The following is a description of a gene set: Transcripts depleted in pseudopodia of NIH/3T3 cells (fibroblast) in response to the chemotactic migration stimulus by lysophosphatidic acid (LPA). species: Mus musculus from publication Mili S, Moissoglu K, Macara IG (PMID 18451862) RNA localization is important for the establishment and maintenance of polarity in multiple cell types. Localized RNAs are usually transported along microtubules or actin filaments and become anchored at their destination to some underlying subcellular structure. Retention commonly involves actin or actin-associated proteins, although cytokeratin filaments and dynein anchor certain RNAs. RNA localization is important for diverse processes ranging from cell fate determination to synaptic plasticity; however, so far there have been few comprehensive studies of localized RNAs in mammalian cells. Here we have addressed this issue, focusing on migrating fibroblasts that polarize to form a leading edge and a tail in a process that involves asymmetric distribution of RNAs. We used a fractionation scheme combined with microarrays to identify, on a genome-wide scale, RNAs that localize in protruding pseudopodia of mouse fibroblasts in response to migratory stimuli. We find that a diverse group of RNAs accumulates in such pseudopodial protrusions. Through their 3' untranslated regions these transcripts are anchored in granules concentrated at the plus ends of detyrosinated microtubules. RNAs in the granules associate with the adenomatous polyposis coli (APC) tumour suppressor and the fragile X mental retardation protein (FMRP). APC is required for the accumulation of transcripts in protrusions. Our results suggest a new type of RNA anchoring mechanism as well as a new, unanticipated function for APC in localizing RNAs. Mouse Gene Set: MILI_PSEUDOPODIA_CHEMOTAXIS_DN, and this is the list of marker genes: Cpsf7 (NCBI Gene Id 77197, cleavage and polyadenylation specific factor 7), Snrnp48, Pcdh19, Pabpn1, Arhgap17, Slc38a10, Lamc1, Sfi1, Slc4a7, F3, Adnp2, Bmp1, Slc19a1, Gpr108, Son, A130012E19Rik, Rpap1, Adora2b, Slc11a2, Cnnm2, Bcl9, Sfpq, Ggcx, Twsg1, Akap1, Slc1a4, P4ha1, Hsd17b12, Fos, Zfyve27, Nisch, Ankrd11, Sri, Cds2, Pisd-ps1, Tap2, Slc10a3, Slc2a10 (NCBI Gene Id 53907), Mfsd11, Galnt18 (NCBI Gene Id 72885), Lime1, Aplp2, Rpn2, Edem2, Ss18l1, Abhd12, Nfib, P2rx4, Slc7a6, Nagk, Alkbh1, Ddr1, Puf60, Fgf7, Ecm1, Rnf10, Fn1, Gm50012, Dpf2, Nedd4l, Pld3, Dhx30, Fgfr1, Npr2, Hnrnpdl, Lmbrd1, Steap3, Chpf2, Cd9 (NCBI Gene Id 12527), BC004004, Noc2l, Fosb, Gla, Tor1b, Cldn9, Rpl30, Ube2i, 5330406M23Rik, Krit1, Neu1, Pdia5 (NCBI Gene Id 72599), Rrbp1, Atat1, Snx14, Atrn, P4ha2, Abcc1, E4f1, Mast4, Col4a1, Slco2a1, Ttc19, Plxnb2, Cyp4f16, Thrap3, Dnaaf9, Cnot3, Ephb4, Kcnq1ot1, Snx29, Dag1, Rnps1, Eif1, B4gat1, Slc29a1, Tctn1, Mfsd9, Sema4c, Birc2, Fzd7, Sigmar1, Nrp2, Ddost, Pik3ip1, Zswim8, Axl, A430046D13Rik, Rpl41, Hmgcr, Ly6e, Phb2, Plxna3, Rack1, Fads3, Gaa, Pofut1, Atp13a1, Col4a5, Esd, Polg, Tm9sf1, Ptpra, Rbm39, Tln1, Sf3b3, Fibp (fibroblast growth factor (acidic) intracellular binding protein), Slc44a2, Ap2a2, Chka, Trim35, Dido1, Cald1, Sec61a1, Baiap2, Igf1r, Cspg4, Tmem109, Tpbg, Klf3, Slc35f6, Spns1, Ackr3, Adamts5, Kdm6b, Gpaa1, Colgalt1, Ppt1, Rusc2, Tm9sf2, Oga, Serpine1, Rps24, Hmgcs1, Angptl2, Syvn1, Srebf2, Tm2d3, Col16a1, Pdgfra, Btg1, Slc38a4, Timp2, Gsk3b, C1s1, Scpep1, Matn2, Fam171a1, H2-DMb1, Serinc1, Med15, Nrp1, Slc35a2, Riok1, Qsox1, Igsf3, Hacd3, Sfswap, Gas5, Clstn1, Naa40 (N(alpha)-acetyltransferase 40, NatD catalytic subunit), Serinc3, Slc20a2, Ppp1r10, Mfsd14b, Slc12a9, Mtch2, Plod1, Nceh1, Slc39a14, Nfkbiz, Arel1, Dhrs7, Clic1, Zdhhc5, Sptlc1, Chuk, Armc9, Atp1a1, Sppl2a, Ltbp4 (NCBI Gene Id 69644), Ranbp3, Abcc5, Adamtsl4, Pla2g7, Clcf1, Prnp, Dolk (dolichol kinase), Trps1, Pan3, Cd109, Rara, Fbln2, Mst1, Pi16, Glg1, Lhfpl2, Tyw1, Slc23a2, Chst12, Ganab, Tmed7, Gcn1, Tlr2 (NCBI Gene Id 24088), Ndel1, 2610005L07Rik, Abca3, Naglu, Akr1b10, Fus, Gmcl1, Mir1949, Itga5, Rbx1, Txndc5, Ldlr (NCBI Gene Id 16835), Mfsd10, Plat, Lrp12, Slc30a6, B3gnt2, H2-K1, Smg5, Pigm, Vcl, Poldip3, Emilin1, Rgs3, Lncppara, Sun2, Khk, Socs3, Erh, Ppil2, Pdia6, Sema3f (sema domain, immunoglobulin domain (Ig), short basic domain, secreted, (semaphorin) 3F, NCBI Gene Id 20350), Hspa5, Wls, Nhlrc3, Grn, Ubtf, Col5a1, Lox, Sec61a2, Thbs1, Sema3b, Vasn, Vcp, Rpn1, Gmpr2, Tnfsf9, Slc16a1, Lrrc8c, Ccnt2, Ttc7, Pdgfrb, Hsf1, Dgcr2, Col4a6, Tubgcp4 (tubulin, gamma complex component 4), Agfg2, Fzd2, Epb41l2, Poglut2 (protein O-glucosyltransferase 2), Malat1, Scfd1, Slc20a1, C1ra, Sgpl1, Selenos, Klf6, Gprc5b, Tmem43, Slc38a2, Thbs3, Serpinf1, Slc12a4, Acvr1, Zzef1, Gnb1, Npc1, Zfp266, Nono, Mpzl1, Tmppe, Elovl1, H3f3b, Pim3, Ctnna1, Sod3, Pcnx3, Usp7, Slc19a2, Pnpla7, Sod1, Kcnn4, Diaph1, Ctnnb1 (catenin beta 1), Ppp6r3, Scd2, Pcdh1, Txnip, Tgif1, Abca2, Mogs, Sgms1, Itga3, Slc39a7, Maco1, Atp10a, Tmem33, Pvr, Chpf, Cdip1, Sun1, Pde7a, Flnb, Pofut2, Slc6a6, Atp5if1, Brms1, Fam53b, Il6st, Mmp11, Katnbl1, Asap1, Ptprf, Ctsb, Snhg3, Acly, Lamb2, Rps10, Pdia3, Ggnbp2, Naga, Gspt1, Mmp14, Scamp2, Ptgs1 (prostaglandin-endoperoxide synthase 1), Clcn4, Matn4, Anxa7, Adrb2, Cux1, Aqp1, Zfp36, Stt3a, Itprip, Slc8b1, Igsf8, Rgmb, Mpg, Ccny, Gpi1, Lgmn, Bclaf1, Bcap31, Snhg1, Htt, Clcn6, Dcbld1, Sned1, Gns, Rab5b, Mir6963, Abcc10, Abca7, Hspa8, Tra2a, Sel1l, Tapbp, Ogt, Snora65, Psap, Msln, Man2b1, Cybc1, Ckap4, Sbno2, Lrp1, Rcn3, Neat1, Mapk8ip3, Itgb1, Eif2ak3, Pkd1, Emc1, Dusp1, Timp3, Alg1, Mir23a, Tenm4, Ero1a, Slc2a1, App, Zmiz1, Sirt3, Actl6a, Esyt1, Dgat1, Pfkl, Degs1, Wwp2, P3h1, Usp53, Ftx, C1galt1c1, Usp14, Por